The following is a description of a gene set: Human Gene Set: GOBP_REGULATION_OF_RESTING_MEMBRANE_POTENTIAL Any process that modulates the establishment or extent of a resting potential, the electrical charge across the plasma membrane, with the interior of the cell negative with respect to the exterior. The resting potential is the membrane potential of a cell that is not stimulated to be depolarized or hyperpolarized. species: Homo sapiens, and this is the list of marker genes: TREM2, KCNJ10, KCNK6, CLCN2, NALCN, KCNK9, KCNJ2, KCNK3, KCNK1, KCNK5 (potassium two pore domain channel subfamily K member 5), KCNK13, ATP1A3, PSEN1